Given this list of marker genes EIF2AK4, CASP10, NLRP1, SPIB, DNASE1 (deoxyribonuclease 1), C4A, BLK, UBE2L3 (ubiquitin conjugating enzyme E2 L3), IL12A, CR2, IRAK1, HLA-DRB1, PTPN22, IL2RA, MECP2, MPV17, FCGR2A, FASLG, CD247, STING1, TNFSF4, FCGR3B (Fc gamma receptor IIIb, NCBI Gene Id 2215), TREX1, IL12RB1, IL2RB, C1QC, POU2AF1, DOCK11, JAZF1, MMEL1, BANK1, MS4A1, TNFSF15, LYN, SLC7A7 (NCBI Gene Id 9056), PTPN2, IRF5, LBR, FCGR2B, TNIP1, KIAA0319L, FAS, IGHG1, PXK, ITGAM, RASGRP1, TNFAIP3, COPA, POMP, PLCG2, IL10, RIPK1, ARPC1B, SPP1, MMP2, C1QB, CTLA4, PLCG1, PRKCD, C4B, TLR7, PDCD1, ACP5, STAT4, CARD10, DNASE1L3, ETS1, LACC1, TNPO3, ANKRD55, CMPK2, SOCS1, GALE, SAT1, CRYAB, here is a description of the gene set: species: Homo sapiens Antinuclear antibody positivity The presence of autoantibodies in the serum that react against nuclei or nuclear components. Human Gene Set: HP_ANTINUCLEAR_ANTIBODY_POSITIVITY